The following is a description of a gene set: Genes predicted to be targets of miRBase v22 microRNA hsa-miR-642b-5p in miRDB v6.0 with MirTarget v4 prediction scores > 80 (high confidence targets). Human Gene Set: MIR642B_5P from publication Chen Y, Wang X (PMID 31504780) species: Homo sapiens, and this is the list of marker genes: PROSER1, TRA2B, KCNJ2, SP100, SLC12A5, ABL2, RHOBTB3, RBM27, BBIP1, ASPH, LDHA, KLF3, ANKMY2, ARHGAP5, ELK4, AP1S2, LATS1, LIN28B (NCBI Gene Id 389421), ADCY6, RREB1, MCEE, MTX3, DACH1, AP3M1, GAN, TENT4B, PRKRA, SLC30A9, PDZD8, PCTP, PRDX6, PRAMEF18, KIF5C, WDR45B, NPTX1, DMTF1, DYNC2H1, ALPL, BRINP3, HAPLN1, NALF1 (NALCN channel auxiliary factor 1), ZNF521, ZMYND11, RFXANK, ZNF800 (NCBI Gene Id 168850, zinc finger protein 800), NIN, SERINC3, DYNLL1, ARRDC3, TNS1, RAP1B, GPATCH2L, AAK1, GABPB2, SLC35B3, GRIA4, KDM3B, EIF1, ROBO1, PTGER2, DNAH9 (dynein axonemal heavy chain 9), ITPR1, JAK2, PHACTR3, PPM1K, CTNNB1, SIRT1, ORMDL3, SEC24D, ZNF544, YTHDF3, ATXN7L3, CALM2, JAG1, AKAP1